The following is a description of a gene set: species: Homo sapiens Any process that activates or increases the frequency, rate or extent of receptor recycling. Human Gene Set: GOBP_POSITIVE_REGULATION_OF_RECEPTOR_RECYCLING, and this is the list of marker genes: NSF, PSEN1, SCRIB, ARAP1, ANXA2, INPP5F, EPS15 (epidermal growth factor receptor pathway substrate 15), SNCA, BVES, RAB29, RAMP3, ECE1, VAMP3, NSG1